The following is a description of a gene set: Human Gene Set: GNF2_CD7 studied in species Homo sapiens Neighborhood of CD7 Neighborhood of CD7 CD7 molecule in the GNF2 expression compendium, and this is the list of marker genes: CD7, KLRK1, NKG7 (NCBI Gene Id 4818), BTN3A3, NPRL2, PRKCH, KLRB1, RORA, PRF1, CTSW, PTGDR, TBX21, MYOM2, PLAAT4, ITGAL, GZMM, KIR2DS2, ZAP70, CD96, IL2RB, PTPN4, SUN2, KLRF1, CD247, IL18RAP, PTGER2, GIMAP6, CST7, CCL4, ABHD17A (abhydrolase domain containing 17A, depalmitoylase), CD160, RUNX3, KLRD1, KLRC3, GNLY, GZMA, ARL4C, GZMH, XCL2